The following is a description of a gene set: A cancer of the prostate. Prostate cancer studied in species Homo sapiens Human Gene Set: HP_PROSTATE_CANCER, and this is the list of marker genes: STAT6, RAD51C, MAD1L1, RNF43, BARD1, MRE11 (NCBI Gene Id 4361), CDKN2A, GREM1, NTHL1, PTEN, AR, KLF6, TP53, RAD51D, RNASEL, EPHB2, BRCA1, NAB2, BRCA2, MXI1, PALB2, APC, AAGAB, RAD50, BRIP1, NBN, RAD51, MDM2, COL14A1, CHEK2, ZFHX3, FOXE1, BMPR1A